The following is a description of a gene set: Genes having at least one occurrence of the motif NNATTGCNNAANNN in the regions spanning 4 kb centered on their transcription starting sites. This matches the CEBPA transcription factor binding site V$CEBP_Q2 (v7.4 TRANSFAC). Human Gene Set: CEBP_Q2 studied in species Homo sapiens, and this is the list of marker genes: NFIL3, MYL1, MAP2K6, SRSF6, PRKG1 (NCBI Gene Id 5592), H3-3B, ZFP36L1, CEP120, ID3, C3AR1 (NCBI Gene Id 719), TRPM1, LHX6, RNF152, OSMR, BEND4, FST, AMTN, PAX6, LMO3, ROGDI, NFKBIA, CSNK1E, CTDSPL2, UBE2E2, NRP2, HMGN2, TOB1, NFE2L2, PRMT3, PER1, PFN2, CBX4, OMD, EDN2, CTSK (NCBI Gene Id 1513), COLEC10, ARHGEF38, NR2F2, SYT4, TTN, TAC1, PDE4D, ITGA11, CHST7, C1QL1, IP6K2, TBX6, TCEAL1, PRRC2A, FCER1G, PLPP5, UBQLN1, ARF6, KCNH7, ZBTB20, CSF3, S100PBP, STAT3, NOL9, CRYZL1, TSHZ3, ANKRD20A19P, CLUH, CEP41 (NCBI Gene Id 95681), G0S2, SUV39H1, OMA1 (NCBI Gene Id 115209), SOBP, SIAH3, JARID2, LRRTM3, CASS4, HTR2C (5-hydroxytryptamine receptor 2C), KRT23, PROS1, LYPD1, TCF4, SBF2, PLA2G4A, CFL2, SNX27, HOXB9, EHF, PRDM16, RUVBL2, CALML4, NEUROG1, ITPK1, CASQ2, RRM2B, MEOX2, HOXB7, ANGPT1, CHD2, STAG1 (NCBI Gene Id 10274), PTPN12, SP6, DDIT3 (DNA damage inducible transcript 3), SRSF2, PCYT2, USP9X, TCF12, RAB3IP, GYS1, ASCL2 (NCBI Gene Id 430), ARHGEF6, ALDH1A2, C2CD5, ATP5F1C, PPP1CB, ITSN1, KRT24, AAMP, CELF4, INPP4A, BDNF, STK40, PCTP, RGN, FOXN3, SPRED1, ELAVL2, CLOCK, RHOBTB2, NHSL2, PDGFRA, OTX2, SLC38A2, HJV, LCOR, PTX3, PDAP1, SLITRK2, SLC1A2, TENT5D, TTC39B, CHAC1, FKBP2, COL13A1, CLU, WDR44, STC1, TBC1D16, MIDEAS, HPCAL1, LONRF3, PLCB1, CYTOR, SHKBP1, CDIN1, CGN, MPPED2, HNRNPH1, CLRN1, SLC25A12, MITF, SFRP2, EIF4A1, PDGFB, YRDC, IER5L, PALS2, HDAC4, NEO1, STX18, SLIT3, MIR137HG, MARCHF1 (NCBI Gene Id 55016), COL4A4, HOATZ, CHST15, MIR22HG, SERPINA7, SMARCA2, S100A8, VAMP1, MAP4, PYGO1, CDKN1C, ODF1, ADRB2, WDR81, FOXP1, TTLL6, LIPG, CLIC4, GPATCH11, ONECUT2, CHM, AFF2, ASAH2, KCNJ13, RASAL2, NFKBIZ, TM6SF1, SYT16, GEN1, NCKAP5, RBPMS, SLC23A1, SLCO1C1, ERLIN1, PTGIS, TXLNG, NEK10 (NIMA related kinase 10), ARNT (NCBI Gene Id 405), SYNJ1, GSK3B, TFAP2D, LRRTM4, PTGR3, CASK, PIP5K1A, TMEM132E, CADM1, PKNOX2, KIN, TBXAS1, PNKD, JADE3, TAS1R1, BUD31, REXO4, THRA, COL4A3, PPP1R3A, DIS3L2, TSC22D1, MAPK14, ZNF423, ATAD2, TCF7L1, FBXW7, SKP2, PDE3B, PURA, FGF14, AHSG, C1orf122